The following is a description of a gene set: Human Gene Set: WP_CALCIUM_REGULATION_IN_CARDIAC_CELLS Calcium regulation in cardiac cells species: Homo sapiens, and this is the list of marker genes: ATP1B2, ADCY8, GNG2, ATP1B1, GJB2, CAMK2G, CAMK2A, CAMK4, SLC8A3, ADCY7, GRK6, ADRB3, ADCY3, GJA5, GJA3, CACNA1A, RGS20, PRKACB, PLN, GJB1, ADRB2, GNAZ, ORAI1, ADCY4, RGS4, GNAS, CACNA1C, CAMK2B, CACNA1D, PRKD1, PRKAR1B, GJC2, ITPR3, GNG8, YWHAE, GNAI3, RGS18, GNB3, CALM3, RGS19, CACNA1B, FXYD2, FKBP1A, GRK4, GNG3, ATP1B3, ADCY2, PRKCH, CHRM5, ARRB1, ADCY9, ADRB1, PRKCA, ADRA1B, GNAQ, ATP2A3 (ATPase sarcoplasmic/endoplasmic reticulum Ca2+ transporting 3), YWHAZ, PRKACA, GJA9, GJA1, CACNB3, PRKAR2B, YWHAQ, GNG5, ITPR1, GNG7, CACNA1S, STIM2, GNAO1, ATP2B2, GJA4, ATP2B1, CALM1, GJB4, YWHAH, CACNB1, RGS5, GJC1, CALR, CALM2 (calmodulin 2), ADCY6, GRK5, PKIA, RGS17, RGS6, ANXA6, PLCB3, PRKCG, ATP2A2, ADCY1, RGS11, RGS10, ADRA1A, CACNA1E, ATP1A4 (NCBI Gene Id 480), SLC8A1, GNG11, GJB3, RYR3, RGS2, CHRM2, KCNJ5, RGS14, KCNB1, PRKCD, CASQ2, CHRM3, CHRM4, CAMK2D, PKIG, GNAI2, RGS3, ATP2B3, GNB2, CAMK1, RYR2, PRKCB, GJB5, ARRB2, GNB4, PRKCE, GNB1, GNG13, RGS9, KCNJ3, GNB5, ITPR2, GNGT1, GNA11, GJA8, GNG4, RGS7, YWHAB (NCBI Gene Id 7529), SFN, RGS1, PRKAR2A (protein kinase cAMP-dependent type II regulatory subunit alpha), CASQ1, ADCY5, PRKAR1A, RGS16, YWHAG, PRKCZ, CHRM1, RYR1, PKIB, GNAI1, GJD2, ADRA1D, GJB6, PRKCQ, GNG12